Given this list of marker genes Srpk2, Malat1, Aff2, Dyrk3, Usp50 (ubiquitin specific peptidase 50), here is a description of the gene set: species: Mus musculus Mouse Gene Set: GOBP_NUCLEAR_SPECK_ORGANIZATION A process that is carried out at the cellular level which results in the assembly, arrangement of constituent parts, or disassembly of nuclear specks, a class of nuclear body in which splicing factors are localized.